The following is a description of a gene set: Mouse Gene Set: GOBP_AMINO_ACID_BIOSYNTHETIC_PROCESS The chemical reactions and pathways resulting in the formation of amino acids, organic acids containing one or more amino substituents. studied in species Mus musculus, and this is the list of marker genes: Gls, Aldh1a1, Mthfd2l, Gad1 (glutamate decarboxylase 1), Aldh18a1, Otc, Mtr, Bhmt1b (betaine--homocysteine S-methyltransferase 1B), Srr, Pycr1, Aass, Gls2, Noxred1, Cth, Abat, Lgsn, Apip, Asns, Asnsd1, Slc38a1, Upb1, Got1, Sephs2, Pcbd2, Plod2, Park7, Ggt1, Nags, Cln3, Slc25a12, Mthfd1, Got1l1, Bcat2, Mri1, Sephs1, Adi1, Cad, Glul, Mthfr, Got2, Tha1, Thnsl2, Atp2b4, Bhmt, Agxt, Psph, Hao1, Dpyd, Phgdh, Pah, Oat, Slc1a3, Psat1, Pycr3, Shmt1, Shmt2, Plod3, Pycr2, Mtap, Cbs, Agxt2, Pcbd1 (pterin 4 alpha carbinolamine dehydratase/dimerization cofactor of hepatocyte nuclear factor 1 alpha (TCF1) 1), Gad2, Bcat1, Ass1, Mtrr (NCBI Gene Id 210009), Aasdhppt, Bhmt2, Asl, Enoph1, Ilvbl, Carns1